The following is a description of a gene set: Genes predicted to be targets of miRBase v22 microRNA mmu_miR_483_5p in miRDB v6.0 with MirTarget v4 prediction scores > 80 (high confidence targets). studied in species Mus musculus from publication Chen Y, Wang X (PMID 31504780) Mouse Gene Set: MIR_483_5P, and this is the list of marker genes: Dok3, Naa11, Ascl4, Zfp580, Fam3d, Klf6, Cenpn